Given this list of marker genes F2, CHGA, PEX5, ABHD17A (NCBI Gene Id 81926), SH3GLB1, MDFIC, RDX, ILRUN, SPAG5, LATS1, LACRT, TIMM10B, RGPD3, MVB12A, ZBTB16, BYSL, NEURL3, PRKACA, CWH43, BBS4, RGPD1, MBTPS1, H2AC4, VWC2 (NCBI Gene Id 375567), ARF4, EZR, BICD1, NABP2, LEPROT, GHSR, RNF186, GOLPH3, PRKN, CRY2, RAB23, TNPO1, NF1, VPS13D, TOMM22, TIMM13, RAP1GDS1, RAB6B, CCDC88A, RAB3GAP2, MARK4, TIMM9, USP36, SUN2, RAB6C, PIK3C3, ZFYVE16, NETO1, PKIA, SLF1, SNF8, FREY1, SGTA, MFHAS1, TRIM37, SEC61G, ESR1, HSPD1, CDK5RAP3, SIX4, RANBP6, KPNA4, ATP5IF1, CCT7, PIK3R4, VPS37C, DAG1, SIRT4, GPC4, NUP155, NOTCH1, LMNB1, SUMO4, BAG6, TSPAN17, ARL3, EMC2, MTX1, XBP1, ZIC1, YWHAB, PEX16, LMNA, CC2D2A (coiled-coil and C2 domain containing 2A), DNAJC19, KPNA3, IPO8, PINX1, AP3B1, KDELR2, CC2D2B, NUP35, RAB29, NUMA1 (NCBI Gene Id 4926), TNKS, INPP5E, RRAGC, CEP350 (NCBI Gene Id 9857), TERF2IP, DCLK2, FAM53B, CCT4, KIF20B, CRIPT, ZDHHC15, SRGN, ZWILCH, LEMD2, MDM2, CSNK2A2, LAMP5, RAB6D, GCKR, RBM22, VCP, H1-5, CAMLG, ROPN1, GAS8, SRSF1, SEC63, ZDHHC5, USP9X (ubiquitin specific peptidase 9 X-linked), CCDC40, MON1B, IPO13, ELAVL1, POM121, H2AC8, LHFPL4, MED1, IPO5, RGPD8, JARID2, PPP3CA, TGFB1, EDN1, H4C9, HAX1, H4C2, TOR1AIP2, OGT, CREBBP, SEC62, BRAT1, NCOA4, VPS26B, ANKRD13C, FKRP, SCG3, PARK7, MDC1, NUP153, TYK2, H4C15, HTRA2, LAMP3, TERF2, CABP1, TMEM201, PPP3R1, RGPD6, LEF1, RAB11FIP3, ZFAND2A, COG3, PAX6, NPAP1, GPC6, DTX3L, MTBP, CEP131, CHCHD4, H2AX, CSRP3, FBXO4, VPS35, TSPO, KPNA1, KPNB1, TAF8 (NCBI Gene Id 135763), SMC5, EZH2, TOMM5, DLG4, CCT5, TAX1BP1, RAB3IP, CLDN18, TOMM70, RAB11A, CTTNBP2NL, KNTC1, AKAP11, PIK3R1, PEX10, GCC2, RPAIN, LNCPRESS1, RYR2, ECT2, GOLGB1, TOR1A, SNUPN, HASPIN, TOMM34, TTK, BID, SSB, ADAR, SRP14, ABRA, SUPT7L, GPAA1, DDX1, MACROH2A2, ARF6, SRP68, CNIH3, APC, TNPO3, CRYZL2P-SEC16B, TTC21A, ANKRD10, CD68, LAMTOR1, NOMO2, BARD1, OSBPL8, VPS37D, DNAH11, TIMM50, BRD3, GIT1, MIA2, TPR, TRAF3IP2, AUP1, BICD2, NUP50, INVS, SGTB, FYN, RAB10, MAN1A1, GBP1, TRIM40, OLFM1, SPIN1, FGF9, MSN (moesin), GGA3, ARL1, CHAMP1, RPL23, SEC61B, PCARE, H4C14, IFT140, CDH1, FKBP8 (FKBP prolyl isomerase 8), INTS8, RANBP2, DVL1, EMC7, SRP72, COL1A1, SHH, PARP3, BRD2, HCLS1, TIMM22, RN7SL2, VEGFA, LEP, CEP83 (centrosomal protein 83), CDK1, CD2AP, MAP1A, WDR19, TIMM23, TTC21B, RAB5IF, FERMT2, KAT7, TMED10, MTCH1, GZMB, RGPD5, SRP9, CHCHD10, TCP1, NUDCD3, HTATSF1, GLI3, TIMM8A, DRD1, HEATR1, MAGED1, SRP19, TCF7L2, FILIP1L (NCBI Gene Id 11259), PML, RHNO1, TOPBP1, SZT2, GLMP, PPHLN1, SUN1, WNK1, MTX2 (NCBI Gene Id 10651), OXA1L, CEP192, GOLPH3L, MFN2, ZDHHC3, POT1, APPL2, INSIG1, CCDC39, FAM149B1, ATG14, TULP2, NUP107, NUP133, GJD2-DT, KIF2C, POM121L2, WRN, JAK1, ATRX, TERT, LIMK2, CFAP58, ZNF423, IL33, LAMP1, CALM3, STK4, PRKAA2, UBL5, IK, ANK2, NSFL1C, SH3BP4, DHX9, EMC1, RAP1A, SREBF2, TMEM108, OS9, ZNF200, TRIM29, TIMM8B, FERMT1, H2BC11, GBP5, TMEM107 (transmembrane protein 107), PMPCA, TBRG1, PAK1, TIMM21 (NCBI Gene Id 29090), DCLK1, DIAPH1, NRP1, RAB7A, CTCF, IPO11, RAC2, EGF, NRARP, CNTLN, PACS1, INTS6, RPA2 (replication protein A2), GBF1, DKC1, TIMM17A, MCM9, TMEM98, CENPQ, EMC3, LMBRD1, TIMM17B, FAM53A, VPS13A, MORC3, EPS15, MEAK7, CENPA, DCLK3, APPL1, RN7SL3, PEX5L, RAD17, TOMM20, SPCS3, SNX10, MACROH2A1, TMED2, LAMTOR4, LAMP2, TOR1AIP1, MAPRE2, GNL3, GRPEL2, APP, CCT8, PKIG, NBN, DDIT3, ATR, CCDC47, ATP13A2, TIMM29, VPS28, PRKAA1 (protein kinase AMP-activated catalytic subunit alpha 1), SYT11, NFKBIA, M6PR, CD81, HNRNPU, GAK, UBXN2B, GET1, NR4A1, RNF128, PRKD1, UBL4B, CEP72, MAP2K1, ARL13B, HACL1 (2-hydroxyacyl-CoA lyase 1), SAE1, H4C11, AP3D1, AP3M1, PARD6A, AIFM1, AP4M1, MIS18A, CARD10, PTTG1IP, EDEM1, WASHC2A, LRSAM1, KPNA6, CACNA2D2, TINF2, H4C4, TOMM6, TRAF6, HERPUD1 (homocysteine inducible ER protein with ubiquitin like domain 1), ARL5A, RB1, MIA3, SEC16B, PPP1R15A, SPG11, MTOR, NOP53, RIPOR1, UBE2L3, DNLZ (DNL-type zinc finger), PAM16, NUP85, GABARAPL2, GAS2L1, ROMO1, AIP, UTP25, SMO (smoothened, frizzled class receptor), PSEN1, CHMP7, ZFAND2B, TRAPPC12, ODAD4, TOMM40L, FBXO7, EHD1, ARL13A, CFL1, FAM47E, FSIP2 (NCBI Gene Id 401024), GLUL, MFF, BAG4, TMCO6 (NCBI Gene Id 55374), NDUFA13, ADAM10, ZMYND10, GET4, CNGB1, NACA, WWTR1, NUP58, WAPL, EMC9, MFSD1, VPS8, RRP7A, RER1, MTERF4, DZIP1, ZNF827, OTUD7B, BAP1, DDRGK1, RCC2, TNFAIP3, BECN1, GPSM2, H4C1, EP300, SP100, CNEP1R1, BOD1, IPO4, NPEPPS, TSG101, OBSL1, NPTX1, SIRT6, PGR, BMP4, MEPCE, ARL8B, HHEX, VPS53 (NCBI Gene Id 55275), EI24, RUVBL2, IFT56 (NCBI Gene Id 79989), PDIA2, RNF4, CCDC66, IFFO1, TXNIP, KPNA5, SLF2, GNL3L, WBP2, PEX26, IPO9, GAS2L2, PEX7, LARP7, INTU, LATS2, TRAM1L1, BRCA2, TCTN1, PIKFYVE (phosphoinositide kinase, FYVE-type zinc finger containing), ASAP1 (ArfGAP with SH3 domain, ankyrin repeat and PH domain 1), LRRK2, ARL5B, RRAGA, HK1, SETD2, IPO7, HDGF, DNAJB6, RPF2, BBC3, FAM83H, ESCO2, TIMM23B, GABARAP, H4C13, PLRG1, JUP, HDAC3, TOLLIP, BUB1B, FAM53C, LRWD1, NUP88, VPS41, NIPBL, AURKB, NOMO1, CCT6A, TPP1, SPDYA, WDR35, MICALL2, RTN4, BCAP29, ORMDL3, TOMM40, DMAP1 (NCBI Gene Id 55929), EPM2A, TMEM147, IFNG, EFCAB7, CDK9, IFT80, VCPIP1, CHMP4B, TFRC, H4C3, RAD21 (RAD21 cohesin complex component), APOD, SYS1, SAMM50, MTCH2, STING1, UBAC2, BBS9, DNAJA1, SGF29, MAPRE3, CBL, RNF31, ANKRD6, MAPT, TULP3, HIKESHI, IMMP1L, SARM1, TSPAN10, UBE2J2, NMD3 (NCBI Gene Id 51068), BAX, SPIDR, VAPA, NGFR, NUP93, RAB6A, RPGR, POM121C, MOAP1, GDI2, PPP1R10, HSPA4 (NCBI Gene Id 3308), ENSG00000283175, ISG15, RABEP1, HSPA5, GDAP1, CDKN1A, RPA1, SRP54, BCL3, TCIRG1, MID2, SPCS1, ACD, XPO1, EIF4ENIF1, CHP2, LUZP1, WRAP53, COX18, MARCHF5, EMC8 (NCBI Gene Id 751), SQSTM1, PHB2, SKP1, HYAL2 (NCBI Gene Id 8692), HK2, FAM83D, CHP1, OPTN, SIAH3, TMEM30A, PAF1, TRIM8, RANBP17, CD36, TMEM126A, SIN3A, NEURL1B, PEX14 (NCBI Gene Id 5195), TESK1, LGI1, TONSL, SEC16A, GRPEL1, VPS13C, TOMM20L, NVL, KPNA2 (NCBI Gene Id 728860), ADCY10, NAGPA (N-acetylglucosamine-1-phosphodiester alpha-N-acetylglucosaminidase), BCS1L, FIS1, TNPO2, DNAJC15, EPB41L3, H4C6, CEP78, CEP250, HPS4, SPATA7, CYREN, NUP214, LAPTM5, NDP, ZPR1, PRKCD, UFM1, TASOR, VPS25 (vacuolar protein sorting 25 homolog), SPCS2, KIAA0753, NETO2, ZFAND6, SUMO1, RAB3GAP1, GLP1R (NCBI Gene Id 2740), HSPA8, VPS11, CCT3, MMGT1, GSK3A, CBLB, ARL2BP, NUP188, IL10RA, GPHN, TIMM44, TRAM1 (NCBI Gene Id 23471), USP7, KDELR3, TOR1B, SESN2, C11orf65, STAM2, LZTFL1, MICALL1, RAB35, HEATR3, PARL, HGS, EMC10, RASSF5, PEX19, PTPN23, TGFB2, ANGPT1, COG7, TSC2 (TSC complex subunit 2), GNPTG, TTC9-DT, GLIS2, BTF3, CDKN2A, UMOD, TRIM69, SIX2, H4C8, RANGAP1, ZBTB7A, TRIM28, SEC61A1, SYNE1, FILIP1, TERF1, ATF2, MSX1, TIMM10, SMAD3, CCT2, XPA, IFT122, PRICKLE1, FBXW7, RGPD2, VRK1, PAQR3, NEDD4, MAPK14, NUAK2, CALR, SREBF1, CACNB4, LILRB4, ZC3H12A, TOMM7, TXN, ABHD17C, STAT3 (signal transducer and activator of transcription 3), WASHC2C, PIBF1, CPE, RAB41, YBX1 (Y-box binding protein 1), NUP54, VPS54, SIX1, PINK1, PIN1, MRNIP, ROM1, UBE2D3, GET3, RAPSN, GPR137B, RRS1, ABCA7, BNIP3L, PPP3CB, POLR1A, NCLN, STK11, CDK20 (NCBI Gene Id 23552), SMURF1, ANKRD13A, MMS22L, GFER, IMMP2L, POLA2, BUB3, LONP2, C2CD3, CSNK1D, RAN (RAN, member RAS oncogene family), CEP68, MAPK15, DYNC2H1, NPHP4, CLU, SRC, ZW10 (NCBI Gene Id 9183), INTS13, H4C16, C1QL3, TCTN2, RAB33B, RALA, RAB8B, SIX3, GFY, MAVS, TUB, TIA1, SORT1, VPS37B, BBS2, HUWE1, MARK3, PEX1, AKT1, TULP1, PCM1, SYK, RCSD1, ARL5C, BHLHE40-AS1, TTBK2, ROCK2, HSP90AA1, KPNA7, AURKA, WASH3P, SPDL1, XRCC4, PYHIN1, TRMT10B, IRGM, RHOU, RGPD4, NR5A1, YAP1, SPI1, ROPN1B, SCARB2, CROCC, PYGO1, MGAT3, PIAS4, SRPRB, TRAM2, CHMP4A, MCM8, MAPK8, BBIP1, VPS4A, MGARP, ABHD17B, PEX12, XRCC5, TP53BP1 (NCBI Gene Id 7158), ERBB2, ENTR1, TNKS2, ABLIM3, NPM1, HOOK3, TAF3, BBS1, MMP12, SNX16, CCDC14, YWHAE, PEX6, POM121B, DCP1A (NCBI Gene Id 55802), MVB12B, DCTN2, ARL2, CTCFL (CCCTC-binding factor like), C1QL2 (NCBI Gene Id 165257), H4C5, ARL6, SEC13, CSE1L, INSIG2, ARFRP1, ING1, MON1A, LAMTOR5, PARP1, MAPRE1 (NCBI Gene Id 22919), DNM1L, KDELR1 (NCBI Gene Id 10945), SNAP25-AS1, MAIP1, APLF, INS, LMAN1, ATG13, NUP62, WDR83OS, PACSIN2, NOL8, PEX3, SSR3, ERBB4, EIF2AK3, NMT1, KNL1, DNAAF11, MIPEP, NUP98, KICS2, PPP1R9B, VPS36, TP53, CACNG2, KCNQ3, EMC6, GGA1, YWHAZ, UBL4A, KLHL21, BCAP31 (B cell receptor associated protein 31), SUFU, SEC61A2, H4C12, TBC1D32, CTDNEP1, FAM76B, IFT20, DZIP1L, TMCO1, AKIRIN2, IQSEC2, DDX3X, ABL1, SORL1, GRXCR2, UBR5, PLK1, CTNNA1, CACNG7, GNPTAB, UBAP1, CDK5, TOPORS, HTR2A, LMNB2, STAM, SPRN, DLG1, MCPH1, ATG9A, FLNA, GSK3B, STIL, NOMO3, E2F3, GBP2, KPTN, CACNG3, SRPRA, HRAS, MCRS1, PIK3R2, RN7SL1, CIZ1, PITRM1, AGK, RAB8A, SUMO3, SPO11, FZD5 (frizzled class receptor 5), DISC1, ATP6V1D, LZTS2 (NCBI Gene Id 84445), ARIH2, STK3, SOX9, ZMYND8, RPL11, VPS37A, NF2, EIF2AK1, PMPCB, PEX2, PEX13, BAG3, TARDBP, HSPA1L, NUTF2, PARP9, EMC4, JAK2, MID1, OBSCN, here is a description of the gene set: Human Gene Set: GOBP_PROTEIN_LOCALIZATION_TO_ORGANELLE A process in which a protein is transported to, or maintained in, a location within an organelle. studied in species Homo sapiens